The following is a description of a gene set: The transcription factor Foxp3 is usually considered the master regulator for the CD4+CD25+ Genes up-regulated in comparsion of ActCD8 versus ActCD8TGF (see Fig. 1 in the paper for details). Human Gene Set: GSE7460_CTRL_VS_TGFB_TREATED_ACT_CD8_TCELL_UP from publication Hill JA, Feuerer M, Tash K, Haxhinasto S, Perez J, Melamed R, Mathis D, Benoist C (PMID 18024188) species: Homo sapiens, and this is the list of marker genes: SMAD3, DNAJA3, DUSP7, BTLA, FLNA (NCBI Gene Id 8272), PTGIS, SLC16A13, SHC1, GOT2, DIO2, PIDD1, DPH2, PDE6C, PRAF2, PLP2, NDUFV3, TESC, ZNF512, ADK, FGL2, OIP5, TMEM45B, EIF2B4, PSIP1, SAAL1, ITGB3, GNAI1, SH2D1A, KAZN, MS4A10, NUP85, PCBP1, AAAS, LPGAT1, TFDP1 (transcription factor Dp-1), RIN3, PUS1, ATP2B1, MAP3K4, CPSF4, ZSWIM1, TAGLN2, EMP3, CSE1L, UTP15, SIRT3, TMED1, ANO10, RORC, PDE1B, FRAT2, CCL24, ZNF418, NEMP1, ECI1, DNAJB2, RRAD, SLC6A3, TLK1, LPCAT1, ZNF22, RPL26, ERCC6L2, HIF1A, PPP5C, FANCB, GGH, HAX1, FBXO4, SLC41A2, LSM5, FAM117B, IER3, NUPR1, TXN2, NUP107, TRPV2, KIFAP3, DAP3, ARRDC2, ID2, SLC19A1, RNPEPL1, LYST, PLXNC1, VARS1, PUS7L, ADAP1, MRE11, ANAPC5, EIF3G, KIF23, DYNLL1, PITPNM3, DSG2, CORO7 (NCBI Gene Id 79585), DCAF1, CD70, TRABD, ANXA1, GUK1, CYC1 (NCBI Gene Id 1537), STMN4, MOK, SERPINA5, FSTL3, AHNAK, CWF19L1, GPN1, RIPK3, RGS9, RBP1, OLFM1, TSEN15, LGALS1, DAPL1, UTP25, PKMYT1, DNAJC17, FOXB1, RPAP3, CAMK4, CCL5, NR4A3, DDX28, UTP14A, MRI1, GTF2H4, EHD3, CD44, IRAG2, GET4, TRMT1, ATP8B4, MMACHC, RERE (arginine-glutamic acid dipeptide repeats), TFPI, SAMD4B, MSH4, SEPHS2, MCM10, STAB2, LDAF1, CAMK2B, MET, EBI3, PLEKHN1, SSRP1, HTR1B, THEMIS2, XIRP1, ACVR1C, SLC25A23, NAV2 (NCBI Gene Id 89797), DSN1, LANCL1, UBE2T, MYO1G, DCDC2, TNFRSF11B, FAM234A, RRP12, CCR2, JDP2, THOC1, RAP2A, TMEM121, CD14, GYG1, PABPC4, GSG1, SLC17A7, OPALIN, FNIP1, CPLX2 (complexin 2), COX6A2, ITGB5, RCE1, PLAUR, CHAF1B, CYSRT1, GNPNAT1, ELMO1, RAB23, ARHGAP29, HEXIM2, SMARCA5, MTM1, GEMIN4, MED21, NCAPH, PDCD2L, NCKAP5L, RNPEP, ANXA2, KCTD12, SCAMP3, DDIT4L, ARHGAP26, POLR2D